The following is a description of a gene set: Mouse Gene Set: REACTOME_ORGANIC_CATION_ANION_ZWITTERION_TRANSPORT Organic cation/anion/zwitterion transport studied in species Mus musculus, and this is the list of marker genes: Slc22a8, Slc22a1, Slc22a7, Slc22a15, Slc22a2, Slc22a16, Slc22a5, Slc22a12, Slc22a3, Slc22a18, Slc22a4, Slc22a6